The following is a description of a gene set: Human Gene Set: GOMF_ER_RETENTION_SEQUENCE_BINDING Binding to an endoplasmic reticulum (ER) retention sequence, a specific peptide sequence that ensures a protein is retained within the ER. studied in species Homo sapiens, and this is the list of marker genes: KDELR1, KDELR3, KCNIP2, KDELR2, CEMIP